The following is a description of a gene set: Human Gene Set: chr2q14 species: Homo sapiens, and this is the list of marker genes: LINC01961, MTATP6P26, RNU7-182P, RNU6-744P (RNA, U6 small nuclear 744, pseudogene), ENSG00000272789, LINC01191, LINC01826, RPL27P7, RNU6-1147P, ELOAP1, MTCO3P43, LINC01941, GLI2, GYPC, CCDC93, RNA5SP103, WBP11P2, RPL23AP7, C2orf76, MTCYBP39, RNA5SP102, MYO7B (NCBI Gene Id 4648), INSIG2, MTND2P21, ZNG1B, ENSG00000271709, GPR17, TMEM37, STEAP3-AS1, MTND4P26, IL37, PROC, ENSG00000286971, TEX51, RPL12P15, CHCHD5, NT5DC4, MTND1P28, VINAC1P, SFT2D3, RNU4-48P, ENSG00000294762, TTL, RNY4P7, EN1, SLC6A14P3, C1QL2, MTND4LP14, CLASP1-AS1, LINC02966, NPM1P32, WASH2P, ENSG00000287937, BIN1, ACRP1, SRMP3, IL36G, CFAP221, NIFK, RNU6-259P, PAX8, TMEM177, LINC01101, MIR4782, PGM5P4, RNU6-1180P, FOXD4L1 (forkhead box D4 like 1), RN7SL111P, POLR1B, IL36RN, LIMS2 (LIM zinc finger domain containing 2), RABL2A (NCBI Gene Id 11159), ZC3H8, DPP10, SLC20A1, ENSG00000287871, UGGT1 (UDP-glucose glycoprotein glucosyltransferase 1), RPL14P6, ENSG00000300287, RPL21P34, LINC02936, MIR4783, SCTR-AS1, PTPN4, RNU6-675P, IL1F10, ENSG00000301329, DBI, RNU6-395P, ACTR3, TFCP2L1, DPP10-AS1, EPB41L5, RPS17P7, CNTNAP5-DT, INHBB (NCBI Gene Id 3625), RN7SKP102, MTND5P22, YWHAZP2, PSMD14P1, RALB (NCBI Gene Id 5899), SLC35F5 (NCBI Gene Id 80255), ENSG00000304529, DPP10-AS2, MTCO1P43, FAM138B, ENSG00000309434, ENSG00000297359, RPSAP23, AMMECR1L, DDX18, ENSG00000238207, SLC20A1-DT, IL36A, RN7SL468P, HTR5BP, ENSG00000297418, DPP10-AS3, LINC01956, HS6ST1, RNU4ATAC, CYP27C1, MAP3K2-DT, ENSG00000286776, RGPD8, IWS1, POLR2DP1, CDK8P2, PSD4, ENSG00000235066, RPL17P15, SAP130, SNRPA1P1, NDUFB4P6, DYNLT3P2, MAP3K2, SEPHS1P7, LINC01823, HMGN2P23, RNU7-190P (NCBI Gene Id 106479096), MARCO, ACTR3-AS1, ENSG00000212182, CNTNAP5, THORLNC, STEAP3, MTND3P10, MIR1302-3, NIFKP9, CKAP2L, IL1B, TMEM185B, SCTR, NIFK-AS1 (NCBI Gene Id 254128), RNU2-41P, ZC3H6, TSN, POLR2D, XIAPP3 (X-linked inhibitor of apoptosis pseudogene 3), IL1A, MTND5P28, DDX11L2, IL36B, AMANZI, RPS26P19, IGKV1OR2-108, IL1RN, ZFP91P1, PGM5P4-AS1, ISCA1P6, WDR33, CLASP1 (cytoplasmic linker associated protein 1), PAX8-AS1, ERCC3